The following is a description of a gene set: Human Gene Set: NUNODA_RESPONSE_TO_DASATINIB_IMATINIB_UP Dasatinib is an ATP-competitive, multi-targeted SRC and ABL kinase inhibitor that can bind BCR-ABL in both the active and inactive conformations. From a clinical standpoint, dasatinib is particularly attractive because it has been shown to induce hematologic and cytogenetic responses in imatinib-resistant chronic myeloid leukemia patients. The fact because the combination of imatinib and dasatinib shows the additive/synergistic growth inhibition on wild-type p210 BCR-ABL-expressing cells, we reasoned that these ABL kinase inhibitors might induce the different molecular pathways. To address this question, we used DNA microarrays to identify genes whose transcription was altered by imatinib and dasatinib. K562 cells were cultured with imatinib or dasatinib for 16 h, and gene expression data were obtained from three independent microarray hybridizations. Almost all of the imatinib- and dasatinib-responsive genes appeared to be similarly increased or decreased in K562 cells; however, small subsets of genes were identified as selectively altered expression by either imatinib or dasatinib. The distinct genes that are selectively modulated by dasatinib are cyclin-dependent kinase 2 (CDK2) and CDK8, which had a maximal reduction of <5-fold in microarray screen. To assess the functional importance of dasatinib regulated genes, we used RNA interference to determine whether reduction of CDK2 and CDK8 affected the growth inhibition. K562 and TF-1BCR-ABL cells, pretreated with CDK2 or CDK8 small interfering RNA, showed additive growth inhibition with imatinib, but not with dasatinib. These findings demonstrate that the additive/synergistic growth inhibition by imatinib and dasatinib may be mediated in part by CDK2 and CDK8. species: Homo sapiens from publication Nunoda K, Tauchi T, Takaku T, Okabe S, Akahane D, Sashida G, Ohyashiki JH, Ohyashiki K (PMID 17213809) Genes up-regulated in K562 cells (bone marrow) after treatment with dasatinib or imatinib., and this is the list of marker genes: CDK9, CCNE1, GADD45B, RAD51, CCND3, NFKB1, E2F5, CASP6, CDK8, STAT3, CCNA2, XRCC4, CDC25C (cell division cycle 25C, NCBI Gene Id 995), CCND2, CDK5R1, XRCC3, NFKBIA, CDC25B, RAD50, E2F4, MYC, CDK4, CDC25A, CASP7, MCL1, BCL2, CDK6, E2F3, CDK13